The following is a description of a gene set: Decreased width of the nasal ridge. studied in species Homo sapiens Narrow nasal ridge Human Gene Set: HP_NARROW_NASAL_RIDGE, and this is the list of marker genes: SMARCA2 (NCBI Gene Id 95083), LMNA, NRAS, HRAS, FOCAD, ADAT3, COL3A1, HNRNPH1, MTX2, CLCN3, FBN1, WDR73, CEP55, ALDH18A1, ZMPSTE24, RECQL, CAV1, POLR3A, PYCR1